Given this list of marker genes GABRA2, TGFBR1, CETN3, NDUFA5 (NCBI Gene Id 80046), ARMCX3, SUCLA2, GLTP, GFOD1, MRPL35, CACNA1H, IQCA1, RNPEP, CD82, SIDT2, RC3H2, DDO, OGDH, ADK, G6PC2, RTN1, B3GNT2, IP6K1, UBE2D1, DMWD, DYSF, NLRP2 (NLR family pyrin domain containing 2), KIAA0087, GFOD3P, DDOST (dolichyl-diphosphooligosaccharide--protein glycosyltransferase non-catalytic subunit), DMXL1, PPM1F, NSMAF, EBAG9 (estrogen receptor binding site associated antigen 9), PPP2R3A, MRPL17, DOCK3, PHACTR2, EMC1, PHACTR4, EVI2A, EIF2B3, CWF19L1, SLC7A7, SGSH, PLEK2, POLQ, GLB1L2, ERI2, GATC, CTSS, DOP1B, RPS6KB2, SAMD4A, STX7, IL36A, KDELR3, BPNT2, IMPDH1, CTSV, AGTR2, CREG1, IDH1, ADCYAP1, ITPKB, GSTM4, CYBA (NCBI Gene Id 1535), ETV5, ACSL3, DCTPP1, SCAMP1, THBS3, NARS1, GSN, MAN2B1, RALGAPA1, CALB2, TESK1, CHSY1, GAK, MKLN1 (muskelin 1), COL10A1, EIF3J, TOMM40, ENPP4 (ectonucleotide pyrophosphatase/phosphodiesterase 4), GFPT1, PSKH1, NDUFA8, LTBR, ANKRD13C-DT, TCIRG1, B4GALT5, DIXDC1, OLR1, HACD3, HDHD5 (haloacid dehalogenase like hydrolase domain containing 5), PGAP3, BAG4, STAB1, LDLRAD4, SPSB1, CKS2, ERP29, MCF2L, GCAT, ABCC3, HADHB, MATK, DBT, BMAL2, EEF1AKMT3, SMC2, DYRK1B, PGRMC1, SERBP1, TOMM70, FASTKD1, DCAF11, FLT1, IRS1, CSPG4, EDEM2, CDH12, TNPO1, SDHC, FADS2, CAST, SPRY4, MAP2K3, MYO9A, MTRR, TRIAP1, IBTK, TNFRSF1B, BANF1, TUBB2A, SLC12A8, FCGR3B (NCBI Gene Id 2215), MIPEP, TSC22D1, PRSS50, PPP1CC, SSR3, ZEB2, ESF1, RBP4, PCK2, RET, PTPN1, SCUBE2, BSCL2 (BSCL2 lipid droplet biogenesis associated, seipin), PPIF, IL6ST, AQP3, BCL10, ASAH1, UBL4A, NRBF2, PPARD, PLA2G4A, MAP4K3, RTCA, MTMR1, GAPDHS, SCML1, GIPC2, MYO5A, PLOD1, VASP, GLRX3, POLD1, LPAR6, NUDCD3, BRD3OS, CD164, FCN1, ERF, DPYD, SLC6A12, ZFP36L1, CAD, CPM, ZZZ3, SCG5, CD101, PROM1, TRAF3, BCAS2 (NCBI Gene Id 10286), CAPN11, MRPL4, UCHL1, ENO1, MYOZ1, PTPN11, MYO1C, AMPD2, GNA11 (G protein subunit alpha 11), INSM1, EPHX1, GATM, here is a description of the gene set: Genes up-regulated in comparison of macrophages versus basophils. In the present study we used Affymetrix oligonucleotide microarrays to produce gene transcription profiles for the major leukocyte types in humans. This comprehensive dataset enabled us to not only establish which genes were expressed in each leukocyte type, but also which genes were expressed in each subset after activation. The used of a comprehensive dataset of gene profiles from all the major human leukocyte subsets enabled a novel and powerful means for identification of genes associated with single leukocyte subsets, or different immune paradigms. from publication Jeffrey KL, Brummer T, Rolph MS, Liu SM, Callejas NA, Grumont RJ, Gillieron C, Mackay F, Grey S, Camps M, Rommel C, Gerondakis SD, Mackay CR (PMID 16474395) Human Gene Set: GSE3982_MAC_VS_BASOPHIL_UP species: Homo sapiens